The following is a description of a gene set: Human Gene Set: GOMF_SEQUENCE_SPECIFIC_SINGLE_STRANDED_DNA_BINDING Binding to single-stranded DNA of a specific nucleotide composition. studied in species Homo sapiens, and this is the list of marker genes: TERF1, RPA2, TERF2IP, RPA1, HNRNPA1, RAD50, PCBP1, HNRNPA2B1, NABP2, STN1, POT1, CTC1, HSF1 (heat shock transcription factor 1), TERF2